Given this list of marker genes SGCB, DAG1, SGCZ, SGCA, SGCE, SGCD, SGCG, here is a description of the gene set: A protein complex that includes alpha- and beta-dystroglycan, which are alternative products of the same gene; the laminin-binding component of the dystrophin-associated glycoprotein complex, providing a link between the subsarcolemmal cytoskeleton (in muscle cells) and the extracellular matrix. Alpha-dystroglycan is an extracellular protein binding to alpha-laminin and to beta-dystroglycan; beta-dystroglycan is a transmembrane protein which binds alpha-dystroglycan and dystrophin. Human Gene Set: GOCC_DYSTROGLYCAN_COMPLEX studied in species Homo sapiens